The following is a description of a gene set: Any process that results in a change in state or activity of a cell (in terms of movement, secretion, enzyme production, gene expression, etc.) as a result of a stimulus reflecting the presence, absence, or concentration of oxygen. Human Gene Set: GOBP_CELLULAR_RESPONSE_TO_OXYGEN_LEVELS studied in species Homo sapiens, and this is the list of marker genes: CASR, NKX3-1, ATF4, ACAA2, NPEPPS, PRKAA1, KCND2, TRPC6, MGARP, CBS, NDUFS2, UCN3, AK4, HP1BP3, TMBIM6, ERO1A, CCNA2, FGFR2, SLC2A4, MDM2, MTOR, BBC3 (NCBI Gene Id 27113), ANKRD1, TBL2, ATP6V1A, EGLN2, BNIP3, SUV39H2, EGLN3, EEF2K, LMNA, DDAH1, CITED2, TMEM199, STAT3 (signal transducer and activator of transcription 3), VASN, MAP2K1, PTGS2, CPEB4, CCNB1, EPHA4, EPAS1, PGK1, UCK2, PTPN1, SIRT2, AQP1, SFRP1, HIF3A, PDK3, SIRT1, NFE2L2, MALAT1, UBQLN1, NONO, NGB, MIR145, RPTOR, MLST8, PDK1, SLC8A3, STUB1, CFLAR, PICK1, PPARG, MIR34A (microRNA 34a), BNIP3L, SUV39H1, NOTCH1, CPEB1, DDR2, STC1, AIFM1 (apoptosis inducing factor mitochondria associated 1), BMP7, PMAIP1, MYOD1, TGFB1, NOP53, MIR17, FABP1, PIK3CB, HIF1A, VEGFA, SLC29A1, OPRD1, DRAM1, CHCHD2, CPEB2, STC2 (NCBI Gene Id 8614), DRD2, CYBB, COMMD1, MIR448, NDNF, ENSG00000274276 (cystathionine-beta-synthase like), FOS, JUND, RORA, SIRT4, CLCA1, ATP6V1G1 (ATPase H+ transporting V1 subunit G1), MSTN, USP19, RWDD3, NDRG1, MIR106B, E2F1, MAP1LC3A, TIGAR, HIPK2, ADAM8, RTN4, BCL2, PRKCE, FOXO1, ENDOG, ENO1 (NCBI Gene Id 81977), INHBA, TP53, MPL, MIR21, MDM4, MIR146A, EDN1, KCNK3, LCN2, ATP6V0A2, PINK1, ANGPT4 (angiopoietin 4), P4HB, TWIST1, HIGD1A, CCDC115, VHL, CAV1, NOL3, MIR20A, AKT1, MIR140, GATA6, PTGIS, AQP3, LPAR1, ROCK2, FAM162A, AJUBA, FAS, MYC, MIR210, SCN2A, GNGT1, ATG7, ATP6V0D1, HILPDA, DNMT3A, S100B, KCNK2, SDHD, IRAK1, PIN1, ZFP36L1, SLC9A1, HYOU1, ADO, TERC, NDP, BAD, MIR214, FOXO3, TREM2, FMN2, RGCC, PPARD, TSC1, MT3, ATP6AP1, MAP3K7, ATF2, BECN1, CBL, TERT, NOX1, EGLN1